Given this list of marker genes FABP7, RTN4, CRYM, HES1, NNAT, SIX6, VIM, MIR9-1HG, TF, PLP1, GAD2, TRIB2, SLC1A3, IRF4, PEA15, PTPRZ1, CLU, BEX1, TTYH1, CDC42EP4, SPON1, CCND1, ATP1A2, CKB, DKK3, RASSF4, NCAM1, MIR9-2HG, RCVRN, SPP1, LGI4, SAT1, MYO10, SOX2, SEL1L3, ZFP36L1, WIF1, GPM6B, PRSS35, SNRPG, ANGPTL1, PMEPA1, here is a description of the gene set: from publication Hu Y, Wang X, Hu B, Mao Y, Chen Y, Yan L, Yong J, Dong J, Wei Y, Wang W, Wen L, Qiao J, Tang F (PMID 31269016) studied in species Homo sapiens Müller glia cells Human Gene Set: HU_FETAL_RETINA_MULLER